Given this list of marker genes PAX2, AMER1, TCF21 (transcription factor 21), WNT4, OSR1, SIX2, STAT1, here is a description of the gene set: Human Gene Set: GOBP_MESENCHYMAL_CELL_DIFFERENTIATION_INVOLVED_IN_KIDNEY_DEVELOPMENT species: Homo sapiens The process in which relatively unspecialized cells acquire specialized structural and/or functional features that characterize the mesenchymal cells of the kidney as it progresses from its formation to the mature state.